Given this list of marker genes DAAM1, CHD8, WNT5A, PPP3CB, LRP5, DVL1, CAMK2A, FZD7, SENP2 (NCBI Gene Id 59343), NFATC2, PRICKLE2, FZD10, NOTUM, CXXC4, PLCB1, WNT2B, GSK3B, FRAT1, CAMK2G, ROR1, TCF7L1, PRKCG, NFATC4, WNT16, LRP6, FZD5, KREMEN1, PLCB3, CTNNB1, CTBP2, PPP3CA, FZD3, CSNK2A3, WNT3, WNT7B, WNT11, AXIN1, TCF7L2, FZD2, PPP3CC, CAMK2D, CSNK2A1, DKK4, SFRP4, NLK, LEF1, WNT5B, DAAM2, CTBP1, DKK2, CER1, INVS, SOST, NKD1, WNT6, NKD2, CTNNBIP1, DVL3, MAP3K7, NFATC1, SFRP5, WNT4, SFRP2, SOX17, FRAT2, MYC, CSNK1A1, MAPK9, JUN, PPP3R2, WNT10B, MAPK8, WNT2, GPC4, NFATC3, FZD9, CSNK2A2, PRICKLE1, RAC1, CCND1, PLCB4, DKK1, SERPINF1, CCND2, CSNK2B, RYK (receptor like tyrosine kinase), ROCK2, FZD6, PRKCA, RHOA, CSNK1E (casein kinase 1 epsilon), CAMK2B, PPP3R1, VANGL2, WNT7A, APC, WNT3A, PLAU, ROR2, SFRP1, WNT10A, WNT1, CCND3, FZD1, DVL2, FOSL1, VANGL1, PLCB2 (phospholipase C beta 2), TCF7, WIF1, PRKCB, PORCN, FZD8, here is a description of the gene set: studied in species Homo sapiens Wnt signaling Human Gene Set: WP_WNT_SIGNALING